Given this list of marker genes FBXW7, PPFIA2, ELMOD1, RCVRN, ANK3, MAP2, NRP1, CELF4 (CUGBP Elav-like family member 4), DLG2, MEIS1, MGARP, MAB21L1, NRXN1, MIR124-2HG, NRXN3, CRABP1, RND3, GRIA2, MLLT11, STMN2, LUC7L3, DPYSL2, MIR9-2HG, TFAP2A, PAX6, RUNX1T1, BEX1, CD24, GRIA4, DIRAS2, SYT1 (synaptotagmin 1), GPM6A, SCG3, RBFOX2, RGS8, MYT1L, NREP, MARCKSL1, GAD2 (glutamate decarboxylase 2), TUBB2B, INA, PCBP3, SRGAP3 (SLIT-ROBO Rho GTPase activating protein 3), RTN1, FAT3, NNAT, SRRM4, TAGLN3, CFL1, TRIB2, CABP1, TUBB2A, NSG2, TFAP2B, SCN3A, RORB, STMN1 (stathmin 1), MEIS2, SOX4, RERE, CCDC88A, LHX9, ZNF385D (zinc finger protein 385D), MIR181A1HG, here is a description of the gene set: Amacrine Cells species: Homo sapiens from publication Hu Y, Wang X, Hu B, Mao Y, Chen Y, Yan L, Yong J, Dong J, Wei Y, Wang W, Wen L, Qiao J, Tang F (PMID 31269016) Human Gene Set: HU_FETAL_RETINA_AMACRINE